The following is a description of a gene set: part of: SARS-CoV-2-host interactions Autophagy is activated during microbial infection to exert antimicrobial defense mechanisms by targeting pathogen-associated components for lysosomal degradation. Pathogens evolved various strategies to manipulate autophagy responses. SARS-CoV-2-encoded proteins, such as open reading frame 3a (ORF3a, 3a) and ORF7a (7a), were shown to colocalize with markers of late endosomal membrane, lysosomal membrane and trans-Golgi network (Hayn M et al. 2021; Koepke L et al. 2021; Zhang Y et al. 2021). Both 3a and 7a block autophagic flux in human cells, but use different strategies (Hayn M et al. 2021; Koepke L et al. 2021). While 7a lowers the acidity of lysosome (Koepke L et al. 2021), ORF3a prevents autophagosome-lysosome fusion (Zhang Y et al. 2021; Qu Y et al. 2021; Miao G et al. 2021). Thus, the SARS-CoV-2 infection stimulates autophagy and leads to an accumulation of autophagosomes but blocks fusion between autophagosome and lysosome thereby preventing degradation of the cargo. In addition, SARS-CoV-2 membrane (M) protein associates with the mitochondrion to promote mitophagy (Hui X et al. 2021). studied in species Homo sapiens Reactome Pathway: SARS-CoV-2 modulates autophagy, and this is the list of marker genes: UVRAG, TUFM, VPS11, VPS18, VPS33B, VPS16, 7a, VPS41, VPS33A, M, 3a, VPS39, MAP1LC3B, VPS45